Given this list of marker genes TARS1, AARS1, ERCC4, RNF113A, XPA, ERCC3, CARS1, ERCC2, DDB2, GTF2H5, ERCC5, FANCE, XPC, FANCC, FANCA (FA complementation group A), FANCD2, GTF2E2, MPLKIP, ERCC6, here is a description of the gene set: An abnormality of the process of DNA repair, that is, of the process of restoring DNA after damage. Human Gene Set: HP_ABNORMALITY_OF_DNA_REPAIR species: Homo sapiens Abnormality of DNA repair